The following is a description of a gene set: species: Mus musculus Mouse Gene Set: GOMF_NUCLEOTIDE_RECEPTOR_ACTIVITY Combining with a nucleotide and transmitting the signal from one side of the membrane to the other to initiate a change in cell activity. A nucleotide is a compound that consists of a nucleoside esterified with a phosphate molecule., and this is the list of marker genes: P2ry6, P2rx1, P2ry1, Hcar2, Gpr34, P2rx2, P2ry4, P2ry13, Gpr171, Ptafr, P2rx7, P2rx4, P2ry2, P2ry14, P2rx6, Gpr87, P2rx3, P2ry12